The following is a description of a gene set: Genes up-regulated in at least one of three multiple myeloma (MM) cell lines treated with the DNA hypomethylating agent decitabine (5-aza-2'-deoxycytidine). studied in species Homo sapiens To identify epigenetically silenced cancer-related genes and to determine molecular effects of 5-aza-2'-deoxycytidine (Aza-dC) and/or trichostatin A (TSA) in multiple myeloma (MM), we analyzed global changes in gene expression profiles of three MM cell lines by microarray analysis. We identified up-regulation of several genes whose epigenetic silencing in MM is well known. However, much more importantly, we identified a large number of epigenetically inactivated cancer-related genes that are involved in various physiologic processes and whose epigenetic regulation in MM was unknown thus far. In addition, drug treatment of MM cell lines resulted in down-regulation of several MM proliferation-associated factors (i.e., MAF, CCND1/2, MYC, FGFR3, MMSET). Ten Aza-dC and/or TSA up-regulated genes (CPEB1, CD9, GJA1, BCL7c, GADD45G, AKAP12, TFPI2, CCNA1, SPARC, and BNIP3) were selected for methylation analysis in six MM cell lines, 24 samples from patients with monoclonal gammopathy of undetermined significance (MGUS), and 111 samples from patients with MM. Methylation frequencies of these genes ranged between 0% and 17% in MGUS samples and between 5% and 50% in MM samples. Interestingly, methylation of SPARC and BNIP3 was statistically significantly associated with a poor overall survival of MM patients (P = 0.003 and P = 0.017, respectively). Moreover, SPARC methylation was associated with loss of SPARC protein expression by immunostaining in a subset of MM patients. In conclusion, we identified new targets for aberrant methylation in monoclonal gammopathies, and our results suggest that DNA methyltransferase and histone deacetylase inhibition might play an important role in the future treatment of patients with MM. Human Gene Set: HELLER_SILENCED_BY_METHYLATION_UP from publication Heller G, Schmidt WM, Ziegler B, Holzer S, Müllauer L, Bilban M, Zielinski CC, Drach J, Zöchbauer-Müller S (PMID 18172295), and this is the list of marker genes: IDH2, LDLR, TOP2A, SOCS1, TRIP6, CFB, FKBP5, KRT7, ZBTB43, DHX8, CEL, AGRN, SERPINF1, CDH11, IRF9, CNTNAP2, UBD, TNFRSF1B, H2AC11, NCAN, CST7, SLAMF7 (SLAM family member 7), CEP15, RIGI (NCBI Gene Id 23586), DAZL, PIP5K1A, ATP13A2, GPR183, ABAT, LAMC2, ARL4C (NCBI Gene Id 10123), BCL6, CSTA, ISG15, TNFRSF9, IFIT1, TNFRSF4, OCA2, ICAM1, CCNG2, IFIT5, GAGE2A, NADSYN1, PLEK, HSPA1A, CCNB1, HERC6, MZF1, IER3, KCNN2, HLA-DRB4 (major histocompatibility complex, class II, DR beta 4), NCF1, IL1R2, ZER1, GPC4, SAT1, PRAME, VCAM1, SSX4, CHRNA1, GPSM2, RNF19B, C5AR1, VAMP8, CD200, S100A13 (S100 calcium binding protein A13), CYP3A5, DDAH2, HLA-DOB, MICAL1, CRYBB1, ADAMDEC1, PPP1R16B, HLA-DQB1, CX3CR1, PLK1 (NCBI Gene Id 5347), IL15, BIRC3, EPHX2, TRIM22, KYNU, XIST, GPNMB, MAGEA4 (MAGE family member A4), SPARC, CIITA, MSR1, TFPT, RAB9A, FOXM1, SYNPO, AURKA, BTN2A2, MYOF, CLEC7A, HCK, DPEP3, OLFML2B (NCBI Gene Id 25903), MAGEA9, CHI3L1, SNN, SSX3, GBP1, LCP1, LRFN4, ST8SIA1, MUC1, USP18 (NCBI Gene Id 11274), SAMSN1, CTSH, CENPF, LPXN, CUL7, H2BC8 (H2B clustered histone 8), HLA-DQA2, S100A6, AKAP12, HLA-DPB1, MIR22HG, MBNL2, PYY, CAPN3, IQSEC3, IL17A, AIRE, SSX1 (SSX family member 1), RPS2, IGFBP3, IL6R, CCNF (NCBI Gene Id 899), APOBEC3F, CYP1B1, HNMT, TANK, PHLDA2, MAP3K6, DAPP1, ARNT2, NR4A3, L1CAM, TBX3, PAEP, NCF2, HLA-DMB, TFF2, CAPG, HLA-DRB1, PACSIN2, RASSF2, HLA-DRA, VCX, UPB1, ZSWIM8, CDKN1A, CCR7, OLAH, IFI44, CDC20 (cell division cycle 20), PLA2G4C, BLK, NCF4, KLF4, PML, PECAM1, CSF2RB, HLA-DRB6, NQO1, IGHA1 (immunoglobulin heavy constant alpha 1), DDX43, LORICRIN, TFPI, LSP1, PRSS2, CLDN3 (claudin 3), H2AC8, SPIB, LAMP3, TKTL1, CDC42EP4, DOK4, PTGER4, BUB1, CTSS, IRS2, WLS, SSTR2, ALCAM, TNFRSF25, MAGEA6, EBI3, SEPTIN9, CLIP2, APOBEC3G, CCL19, HLA-DMA, ID1, HLA-DQA1, ARRB1, IZUMO4, IFIT3, IL13RA1, ALDH2, MAGEC1, CDH1, DENND5A, GATA3, CACNG3, S100A4, S100P, MAGEA12, TUBB2A, HSD17B1, FUT7, DDX60, CELSR1, ENPP2, IFIH1, TSPAN15, MMP9, IFI44L, CXCL10, TNFRSF11A, SMARCA1, SIRPA, IFI27, H3C4, PMAIP1, CYRIA, IL3RA, TDRD12, IL32, MYO9B, FBN1, SMG7, TADA3, DOCK10, RAB13, CSAG2, IGFBP4, BMP2K, TNFAIP6, SURF2, GPM6B, TNFAIP2, RELN, REL, CFP, MCAM, SSX2, COL9A2, MAGEA3, IFITM1, MAGEB1, DNMT3L, GCNT3, STAT1, HLA-DPA1, SBNO2, NCR2, MAP3K8, PRF1, CD1E, TMT1A, CLU, APOC1, NRXN1, ADAM19, ATF7IP2, CXCL13, SOCS3, RGS13, MAFB, MX1, CD86, PDE4DIP, APOE, CEP55, TBRG4, ISG20, TCTN1, RGS1, PIK3CD, FSCN1